The following is a description of a gene set: Human Gene Set: GCM_TPR species: Homo sapiens Neighborhood of TPR Neighborhood of TPR translocated promoter region (to activated MET oncogene) in the GCM expression compendium, and this is the list of marker genes: DHX9, SP3, IDH3A, KHDRBS1, TRA2B, PCBP1, ZNHIT3, TSN, CTR9, RAD21 (RAD21 cohesin complex component), POLR2B, PCM1, TPR, DHPS, CAPRIN1, DDX39B, PTGES3, ARCN1, WAPL, CALM2, TRIM26, FUS, MEN1, PI4KB, IARS1, MPV17, COPA, SF1, SETDB1, PSMD11, DDX18, PPP1CC